Given this list of marker genes FKBP5, SLMAP, SKIL, MMGT1, ODF2L, SEPTIN7, ANLN, TMEM182, PRKG1, HBS1L, ZNF91, CDKN2AIPNL, SIK3, GLO1, STRBP, AGL, NUMB, FGL2, CHML, GPR158, KMT2D, RAB3B, FSD2, CNEP1R1, CCN2, CFL2, MEP1A, JMJD1C, BNIP2, MCU, AK2, POLR1D, PNPO, FSD1L, MOB1A, TERF1, OCSTAMP (osteoclast stimulatory transmembrane protein, NCBI Gene Id 440764), INSYN2A, DPP4, GOLGA6L1, MAP2, SPIN1, CUL4B, IPO7, SLC4A7, TNKS2, CREBBP, ARL8A, BOLL, CREB1, MTSS2, EOGT, SLC2A13, PGAP1, TMED7, GULP1, TFEC, NOVA1, LIN7C, RAB4A, BNC2, MICAL2, GLMN, ERLIN1, KLHL20, MCTS1, BMP3 (NCBI Gene Id 651), PKIA, AIPL1, FAM199X, CXCL12, ZNF284, ATP2B1 (ATPase plasma membrane Ca2+ transporting 1), GJA3, CLOCK, CSNK2A1, TRIM59, PRMT6, KLHL28, PTPN11, STX17, ATAD2, TRIM49 (tripartite motif containing 49), ABI3BP, ECHDC1, HNMT, GDPD1, SAXO2, SMAD9, GOLGA6L6, VAMP4, CCDC179, ZSCAN20, PKHD1, EDIL3, CADM2, HTN1, SH3TC2, ZNF624, PIAS2, ZNF644, CAMK4, COX15, SMAD5, CCDC39, LRRTM2, SPAG9, ZNF507, CENPJ, ATRX, TAFA2, KDM7A, MYSM1, ARFGEF3, MAP3K21, IGFBP5, SGIP1, TP53TG3B, CLEC6A, SEC24A, SLC35E3, ATXN10, ZMAT3, UBE2F, UBE2E2, EFCAB13, DCX, PRSS23, UBA3, YTHDF3, FBXL7, APH1B, USP31, PIP5KL1, USP15, DPY19L1, CLDN16, SNX3, THSD7B, AEBP2, BRPF1, PRELID2, TDG, INSYN1, ZIC4, DLX6, RAP2C, CACNA2D1, PPP1R11, INTS2, STAM, PPP1R3A, CGGBP1, PDLIM5 (NCBI Gene Id 10611), TCEANC, HECTD2 (NCBI Gene Id 196026), CYCS, MBNL2, DENND10, CAND1, FAT3, KITLG, DCTD, BAMBI, RFX3, TRIM49D2, TRIM33, ASPH, NIN, CSTA, GNAI3, ADAMTS5, HYCC2, CD84 (NCBI Gene Id 8832), KMT2E, CCBE1, TRIM48, ATP10A, SSH2, CYSLTR1, RNF2, TOX, GRID2, FUT9, ITGA1, CEP120, CYRIB (NCBI Gene Id 51571), PIKFYVE, DOCK2, GOPC, ARHGAP5, CBX6, CAT, OGN, XRN1, IKZF5 (NCBI Gene Id 64376), RFX5, SYAP1, ZBED4, TANC1, ABI1, CDH11, MORF4L2, SURF4, ZCWPW2, ITCH, THAP6, MSI2, TRIM49C, EFHC2, EEA1, TP53TG3D, CCN4, BMPR2, NR6A1, HOOK3, RRM2B, SLF2, BRWD1, SOX6, DCLRE1A, HS2ST1, GPM6A, LIN7A, AMBN, UBASH3B, SH3KBP1, IFNW1, CDH10, CXADR, E2F4, TRIM51, SEPHS1, ZNF426, TFDP2, SSR1, ZNF706, RNLS, MBNL3, ASXL1, GPBP1, SNAP23, SEMA3D, NT5C1B, ADARB2, RNF145, EDAR, ZBTB14, ERCC4, ZNF721, PABIR2, ZNF621, OSR2, ROCK1, CSMD3 (CUB and Sushi multiple domains 3), SLC12A2, UPRT, GIMAP2, MFAP5, WDFY3, MCTP2, GPC6, SUPT4H1, MAP1B, CCDC88A, EIF1AX, GUCY1A1, PRP4K (NCBI Gene Id 8899), NKAIN1, WWC2, TP53TG3, GDNF, ATG3, GPD1L, EPHA5, CUL3, CPB1, GABRA1, VIPAS39, KLHDC8A, RAB8B, PIK3R1, EPHA4, BTC, LYN, AKAP11, MAPK9, EVI5, FAT4, ROR1, CLIP1, NCBP2, PCSK5, LRRC40 (NCBI Gene Id 55631), IGDCC4, PUM1 (pumilio RNA binding family member 1), FRMPD4, FZD3 (frizzled class receptor 3), NSG1, PPP3CB, MMP24, CLRN3, ACSL6, OSBPL8, BEND4, LNX2, TPK1, SLC26A7, ZNF529, NDFIP2, MRPL42, STRN, here is a description of the gene set: Genes predicted to be targets of miRBase v22 microRNA hsa-miR-1252-3p in miRDB v6.0 with MirTarget v4 prediction scores > 80 (high confidence targets). from publication Chen Y, Wang X (PMID 31504780) studied in species Homo sapiens Human Gene Set: MIR1252_3P